Given this list of marker genes POGZ, GNPTAB, PUF60, SON, PLCB4, RYR1, PIGU, MYO18B, CDH11, PPP1CB, NUP133, SPEN, UGP2, CLP1, SPOP, WWOX, CTU2, SPTBN1, ZFX, PWRN1, LIG4, SNORD116-1, SLC16A2, AP4E1 (adaptor related protein complex 4 subunit epsilon 1), PPP2R3C, SMC3, MTSS2, MAD1L1, IFT140, WDR35, WBP4, TBCD, CCDC47, NUP107, ATN1, NAA20, SMARCD1, ABL1, IER3IP1, CAMK2B, KIF26A, SLC12A2, AFG2B, ZNF148, SETBP1, FAT4 (FAT atypical cadherin 4), KCNK9, GPT2, USP9X, DNM1, HS2ST1, CTCF, SNORD115-1, CDKL5, RAB3GAP1, LMNB1, DHCR7, RBBP8, TBCK, GET4 (NCBI Gene Id 51608), HNRNPK, CARS1, MEIS2, TRAPPC4, SIM1, COG7, LAGE3 (NCBI Gene Id 8270), GTPBP2, H4C9, MADD, MAPK1, GPAA1, SOX6, CACNA2D1, HERC2, AXIN1, AP4M1, MN1, ERI1, BRAF, NRCAM, SMPD4, VPS53, H3-3A, SMG9, SPRED2, WDR26, SLC12A6, KAT6A, HS6ST2, NBAS, FUT8, ZIC2, DOCK7, QARS1, PLAA, LZTR1, AMPD2, KATNB1, NPAP1, ERF, DTYMK, CDC42, ATRX, NIPBL, MAP2K2, TUBGCP2, NUP188, BICRA, DDX6, ELN, NAA10, GON7, RTL1 (NCBI Gene Id 651665), PUM1, OSGEP, RNU4-2, KDM4B, EBF3, TCF4, GOLGA2, MAPKAPK5, DDX11, DCHS1, TSPEAR, FGFR1, RELN, BMP2, PIGB, CNTNAP2, PIGN, DHCR24, PRKAR1B, PSPH, SERPINH1, ATP6AP2, FREM1, ESAM, NF1, SNRPN, CCDC88A, PIGY, AP4B1, LETM1, SLC25A46, DPH5, TRMT10A (tRNA methyltransferase 10A), COL18A1, MLXIPL, AP4S1 (adaptor related protein complex 4 subunit sigma 1), SC5D, TNPO2, LGI4, CRELD1, PWAR1, MAGEL2, TRAPPC9, ASXL1, MEG3 (NCBI Gene Id 55384), ASPM, RNF13, AFF4, DLK1, PYCR2, ADAM22, SHOC2, TMCO1, RARS2, FRA10AC1, MKRN3, NEXMIF, DYRK1A, PURA, PPP1R15B, FRMD4A, SMC1A, AMER1, PPP1R21, AHDC1, PPP2R5D, MYOD1, KCNK4, NDE1, SUOX, MED13L, TBC1D24, GNB2, ZNHIT3, EPG5, CAMK2G, PIGT, here is a description of the gene set: Narrow forehead Width of the forehead or distance between the frontotemporales is more than two standard deviations below the mean (objective); or apparently narrow intertemporal region (subjective). studied in species Homo sapiens Human Gene Set: HP_NARROW_FOREHEAD